The following is a description of a gene set: studied in species Homo sapiens A developmental defect in which the legs are fused together. Sirenomelia Human Gene Set: HP_SIRENOMELIA, and this is the list of marker genes: GREB1L (NCBI Gene Id 80000), GFRA1, FGF20, DACT1, TBC1D24, ATP6V1B2, AKT1, RET, ITGA8 (NCBI Gene Id 8516), WNT9B